Given this list of marker genes MRPL22, SANBR, SAR1B, PSIP1, CAPNS2, EFCAB7, HMBS, EBI3, DDR1, ETAA1, CHEK1 (checkpoint kinase 1), TMEM168 (NCBI Gene Id 64418), COPRS, THOC6, RIPK3, RAN, ASCC3, CHML, CRYBG2, ITGB3, TESC, SOWAHC, ICOS (NCBI Gene Id 29851), CYP51A1, SDF4, UBE2N, HPRT1, PLK4, FIGNL1, EMC7, TFB1M, TRAF3IP2, SKA3, COPS7A, NAT14, URB2, OSBPL3, GTF2E2, BUB1, CRLS1, TRIP13, DDOST, EMB, WBP4, DZIP1, PDGFRB, CEP55, METAP2, TRDMT1, C1QTNF12, C2CD5, HAUS6, EIF2D, SLC25A33, HNRNPA3, MTHFD1L, PSMD12, TACC3, KRT32, PPP1R3F, SEC24D, NEIL3, IL18RAP, STOML2, HAUS4, ENPP4, ENOPH1, AIMP2, EIF3J, RIOK1, KCTD12, ANXA2, HIF1A, C9orf43, EIF2S1, SFPQ, PICALM, UCHL5, PDE5A, FIRRM, GLIPR1, DONSON, WWP1, IFT81, TBC1D19, PBK (PDZ binding kinase), PLAUR, NCAPD3, DEPDC1, PGLYRP1, CENPU, KCTD9, SLBP, ERP44, GIMAP8, GFPT1, CORO6, MYBL1, ANKRD13C, ARHGEF10, RIF1, CIP2A, NUDT19, JADE2, TMED3 (transmembrane p24 trafficking protein 3), SMC4, GRSF1, PDSS1, USP1, PIF1, SPDL1, CLCC1, RCSD1, AGTPBP1, FERMT3, DHFR, NABP1, PALS2, MS4A6A, ATP10A, STT3A, LTN1, TMCO1, NCOA7, AGT, PLAGL1, DNAAF2, CYB561D2, DPP9, CCSAP, SERINC3, ADK, ANLN, EXOSC3, LRP8, TNK2, LINC02393, ABI2, PSMC1, MTFR2 (NCBI Gene Id 113115), SLC39A6, NBN (nibrin), RBMXL1, GRAMD1B, TMX1, CYB5B, ESCO2, DNTTIP2, VILL, ST3GAL5, NHEJ1, MTM1, STK39, PTCH1, WDR74, HNRNPAB, C6orf89, NOLC1, VPS26C, SLC16A1, TMPO, TMEM229B, KIF18A, ORC1, TENT5A (NCBI Gene Id 55603), PSAT1, ROM1, POLA2, PIMREG, MCM3, POLK, TMEM181, P4HB, FAM72A (NCBI Gene Id 729533), ABHD8, ZNF777, AFG3L2, PKP4, SEPTIN6, ATAD5, TM2D1, MAP3K20 (NCBI Gene Id 51784), ID2, KRR1, NAB2, SLA, PTGER2, RAD54B, TEX30, TGM1, TBL2, DDX39A, MLX, GGH, CCNE2, SELENOI, ZCCHC8, STX7, PINX1, TSPYL4, here is a description of the gene set: Genes up-regulated in comparsion of ActTreg versus ActTregTGF (see Fig. 1 in the paper for details). from publication Hill JA, Feuerer M, Tash K, Haxhinasto S, Perez J, Melamed R, Mathis D, Benoist C (PMID 18024188) studied in species Homo sapiens The transcription factor Foxp3 is usually considered the master regulator for the CD4+CD25+ Human Gene Set: GSE7460_CTRL_VS_TGFB_TREATED_ACT_TREG_UP